The following is a description of a gene set: Mouse Gene Set: GOBP_NEGATIVE_REGULATION_OF_CD4_POSITIVE_ALPHA_BETA_T_CELL_DIFFERENTIATION Any process that stops, prevents, or reduces the frequency, rate, or extent of CD4-positive, alpha-beta T cell differentiation. species: Mus musculus, and this is the list of marker genes: Foxp3 (NCBI Gene Id 20371), Runx1, Anxa1, Rc3h2, Il4ra, Zbtb7b, Tbx21, Cd69, Tnfsf4, Lgals1, Jak3, Bcl6, Irf1, Cbfb, Hmgb1, Smad7, Socs5, Zc3h12a, Il4, Ascl2, Rc3h1, Loxl3, Pf4, Zfp35, Hlx, Il2, Tnfsf18, Runx3